The following is a description of a gene set: NAD biosynthesis II from tryptophan studied in species Homo sapiens Human Gene Set: WP_NAD_BIOSYNTHESIS_II_FROM_TRYPTOPHAN, and this is the list of marker genes: QPRT, TDO2, NADSYN1, KYNU, KMO, AFMID, NMNAT1, HAAO